Given this list of marker genes DNASE1L1, DNASE2B, DNASE1L2, TREX1, DNASE1L3, DNASE1, DNASE2, here is a description of the gene set: Human Gene Set: KEGG_MEDICUS_REFERENCE_DNA_DEGRADATION_BY_EXTRACELLULAR_ENDOLYSOSOMAL_DNASE species: Homo sapiens Pathway Definition from KEGG: (TREX1,DNASE1,DNASE2) -| DNA DNA degradation by extracellular/endolysosomal DNAse. Pathway ID: N01571. Pathway type: Reference. Pathway class: nt06520 CGAS-STING signaling.